The following is a description of a gene set: Mouse Gene Set: GOBP_TORC1_SIGNALING studied in species Mus musculus A series of intracellular molecular signals mediated by TORC1; TOR (target of rapamycin) in complex with at least Raptor (regulatory-associated protein of TOR), or orthologs of, and other signaling components., and this is the list of marker genes: Mlst8, Sesn2, Ctns, Shq1, Foxp1 (NCBI Gene Id 73231), Otub1, C9orf72, Ube3a, Gpr137b, Tsc1, Wdr24, Nlk, Fnip1, Npc1, Rps6kb2, Itfg2, Hoxb3os, Rps6kb1, Alg13, Rps6ka5, Srms, Lamtor3, Stambpl1, Rragb, Wac, Bmt2, Klhl22, Nprl2, Prmt1, Rps6ka1, Akt1, Dgkq, Syk, Stk11, Ube2d1, Usp4, Prkaa2, Smcr8, Rbx1-ps, Mfsd8, Rraga, Src, Akt1s1, Slc38a9, Sik3, Lars1, Vhl, Cul3, Ywhag, Atxn3, Mat2a, Prkacb, Peli1, Nprl3, Gpr137, Rps6ka2, Kptn, Ube2w (NCBI Gene Id 66799), Lamtor4, Szt2 (NCBI Gene Id 230676), Gpr137c, Spaar, Fnip2, Ep300, Prkaca, Rragd, Depdc5, Tbk1, Sesn3, Flcn, Castor2, Sesn1, Tsc2, Pip4p1, Rps6ka6, Usp7, Larp1, Ywhaz, Rnf152, Card11, Mapk3, Rnf167, Rragc, Sar1b, Mtor, Deptor, Sec13, Lamtor2, Pih1d1, Lamtor1, Otud7b, Lamtor5, Csnk1a1, Rbx1, Dyrk3, Castor1, Tbc1d7, Sar1a, Usp32 (ubiquitin specific peptidase 32), Atm, Rps6ka4, Ogt, Clec16a, Ube2n, Rheb, Kics2, Ppdpf, Wdr59, Prkaa1, Otud5 (NCBI Gene Id 54644), Mios, Rptor, Seh1l, Rps6ka3, Gpr155, Pten, Pim1